The following is a description of a gene set: from publication Abbas AR, Baldwin D, Ma Y, Ouyang W, Gurney A, Martin F, Fong S, van Lookeren Campagne M, Godowski P, Williams PM, Chan AC, Clark HF (PMID 15789058) Immune cell-specific expression is one indication of the importance of a gene's role in the immune response. In order to identify such patterns, we set out to broadly profile gene expression in a variety of immune cells. species: Homo sapiens Genes down-regulated in comparison of unstimulated NK cells versus those stimulated with IL15 at 16 h. Human Gene Set: GSE22886_UNSTIM_VS_IL15_STIM_NKCELL_DN, and this is the list of marker genes: PSMB5, TUBB4B, HAT1, HSPA14, MCM4, RPA3, ASCC3, UBE2M, STIP1, MRPS7 (mitochondrial ribosomal protein S7), SLC39A1, CCT5, CCT6A, SHMT2, CRELD2, PSMC3, APOO, USP16, SUV39H2, FDX1, LDLR, SUCLA2, ITPRID2, CD226, POLD2, SMC4, GMNN, SLC7A1 (solute carrier family 7 member 1), ELOVL6, UBE2S, COPS3, MRPL17, EIF2S1, ELAVL1, CTNNAL1, SFXN1, EPRS1, MCM7, HDAC2, HSPD1, BCAT2, MRPL15, CISH, PPP2R1B, RAN, MSH6, ENOPH1, IL4R, PCNA, XRCC5, SLC39A8, NDUFA6, POLR2H, SARS1, HMGCR, POLD1, ARMC1, UTP11, KPNA2, MCM6, MRPL39, NUP205, IARS1, IPO7, NUTF2, MCM10, TIPIN, CDC20, MED20, MAD2L1 (mitotic arrest deficient 2 like 1), SNRPB, RFC4, TUBA1B, ASNS, TUBA3C, WDR12, HMGXB4, TOPBP1, PGRMC1, PSMD6, TEX30, SNRPG, MRPS15, MCM5, STOML2, CCT2, NME1, MTHFD1, NUP37 (NCBI Gene Id 79023), MANF, CKS2, FEN1, CCT8, PAICS, TNFRSF12A (NCBI Gene Id 51330), TCP1, GZMA, ZZZ3, HNRNPAB, CTPS1, CSE1L, PSMC5 (proteasome 26S subunit, ATPase 5), CDT1, PRNP (NCBI Gene Id 96713), VBP1 (NCBI Gene Id 7411), WSB2, UBE2N, PRC1, LTB, EBNA1BP2, DPP4, GRPEL1, CDK4, ORC1, PA2G4, CCT7, CKS1B, DCTPP1, SLC1A4, MCM2, TPM4, RANBP1, POLR3K, CENPS, ZMPSTE24, DNMT1, UGDH, DNAJC9, MSMO1, NELFE, USP14 (ubiquitin specific peptidase 14), TMEM97, PPAT, NIPA2, SQLE, NSDHL, H2AX, STX3, GLRX2, ATP1A1, XPOT, CORO1C, CDK2AP2, WDR1, USP1, MLEC, ENO1, TFDP1, MTCH2, PSMC4, ALG5, MCUR1, TRIP13, EIF3J, CDK2, BCL2L1, GGCT, JPT2, LTA, CIAO2B, TUBG1, TUBGCP3, GNL2, NUP58 (nucleoporin 58), GLRX3, FH, RBBP8, PSMB6, MRPL35, DTL, DPP3, SLC39A14, SLC1A5, PRDX3, MMD, CDC6, PSMD14 (NCBI Gene Id 10213), MAT2A, BLM, SLCO4A1, EEF1E1, CPD, VDAC1, NUP98, VIM, MRPS35, CDC45, DCLRE1A, RFC5, RAD51AP1, LMNB2, UXS1, GPN3, NASP, PAK1IP1, PBK, FANCE, DONSON, GINS2, UBA2